The following is a description of a gene set: Global Genome Nucleotide Excision Repair (GG-NER) Human Gene Set: REACTOME_GLOBAL_GENOME_NUCLEOTIDE_EXCISION_REPAIR_GG_NER species: Homo sapiens, and this is the list of marker genes: CHD1L, UBE2I, RPS27A, SUMO1, CETN2, ACTL6A, DDB1, XPC, GPS1, YY1, RFC1, XRCC1, POLE2, PIAS1, POLE, RFC4, ERCC1 (ERCC excision repair 1, endonuclease non-catalytic subunit), ERCC4, INO80D, INO80, INO80E, POLD3, POLE3, GTF2H1 (NCBI Gene Id 2965), COPS5, PCNA, COPS2, GTF2H4, PARP1, UBA52, UBE2V2 (NCBI Gene Id 7336), TFPT, CDK7, ACTB, POLD4, NFRKB, PARP2, RAD23B, RBX1, UBB, RFC5, ACTR8, ACTR5, COPS3, INO80C, SUMO3, RNF111, RUVBL1, POLD1, GTF2H5, GTF2H2, ERCC2, PIAS3, MNAT1, RAD23A, INO80B, USP45 (NCBI Gene Id 85015), RFC3, POLK, RPA1, POLD2, RFC2, CUL4B, UBE2N, COPS4, DDB2, RPA2, RPA3, GTF2H3, CUL4A, COPS7A, ERCC3, POLE4, UBC, ERCC5, COPS8, COPS6, MCRS1, LIG1, COPS7B, SUMO2 (small ubiquitin like modifier 2), CCNH, XPA, LIG3 (DNA ligase 3)